The following is a description of a gene set: Human Gene Set: GOBP_POSITIVE_REGULATION_OF_VIRAL_PROCESS studied in species Homo sapiens Any process that activates or increases the frequency, rate or extent of a multi-organism process in which a virus is a participant., and this is the list of marker genes: CLEC4G, RSF1, LGALS9, CD74, STOM, FURIN, TRIM21, NOTCH1, RAD23A, VAPB, SMPD1, MDFIC, TOP2A, CNOT7, CD4, TMPRSS2, KPNA6, PPIE, NR5A2, KPNA2, TYRO3, ADAR, TRIM38, VPS37B, PPIA, DDX3X, CD209, TMPRSS4, TMEM250, ATG12, FKBP6, STAU1, FMR1, SRPK2, PPID, SRPK1, PABPC1, IFIT1, P4HB, CCL5, PKN2, ADARB1 (adenosine deaminase RNA specific B1, NCBI Gene Id 104), HLA-DRB1, TSG101, GBP7 (NCBI Gene Id 388646), LARP1, BSG, RAB7A, TARBP2, CD28, AXL, TBC1D20, HACD3, PPIH, LGALS1, DHX9, HMGB1, TRIM11, TMEM39A, TOP2B, VPS4A, DDB1, ATG5, PDE12